The following is a description of a gene set: Comprehensive identification of all functional elements encoded in the human genome is a fundamental need in biomedical research. Here, we present a comparative analysis of the human, mouse, rat and dog genomes to create a systematic catalogue of common regulatory motifs in promoters and 3' untranslated regions (3' UTRs). The promoter analysis yields 174 candidate motifs, including most previously known transcription-factor binding sites and 105 new motifs. The 3'-UTR analysis yields 106 motifs likely to be involved in post-transcriptional regulation. Nearly one-half are associated with microRNAs (miRNAs), leading to the discovery of many new miRNA genes and their likely target genes. Our results suggest that previous estimates of the number of human miRNA genes were low, and that miRNAs regulate at least 20% of human genes. The overall results provide a systematic view of gene regulation in the human, which will be refined as additional mammalian genomes become available. Genes having at least one occurrence of the highly conserved motif M26 TTAYRTAA in the regions spanning 4 kb centered on their transcription starting sites. This matches the NFIL3 transcription factor binding site V$E4BP4_01 (v7.4 TRANSFAC). from publication Xie X, Lu J, Kulbokas EJ, Golub TR, Mootha V, Lindblad-Toh K, Lander ES, Kellis M (PMID 15735639) species: Homo sapiens Human Gene Set: TTAYRTAA_E4BP4_01, and this is the list of marker genes: NEGR1, PELI2, BSN, NPTX2, ZBTB7A, SLC24A2, SPRED1, AK3, SMAP2, ETV5, ETV4, FBXW7, SECISBP2L, NEUROD6, NMT1, MID1IP1, MED12L, FKRP, WDR47, CREB5, WDR81, LARP7, SYT14, SUMO1, ERGIC1, IL34, PRDM8, STK35, ARG2, H1-5, C1QTNF7, ELOVL6, CYLD, KCNIP4, MSRB3, CDK8, CALM1, YTHDF3, RGS6, FST, ARRDC3, FAIM2, NFIL3, GPM6A, RSKR, ANKRD40, CTDSP2 (CTD small phosphatase 2), PGK1, RBFOX2, LONRF3, UNC5C, HS6ST2, CREBRF, LHX6, DAGLA, INPP4A, PCSK2, BCL11A, PPFIA1, WEE1, NPTX1, CADM1, NRSN1, RASL10B, MIOX, ENAM, GNPNAT1, HERPUD1, DPM1, NDST3, TFEB, ALDH1A1, CFAP161, SIAE, NAPEPLD (NCBI Gene Id 222236), RGL1, ZDHHC14, PTHLH, FAM76A, ID4, MAP2K3, TSC22D1, AP1S2 (NCBI Gene Id 8905), MOCS3, USP2, EIF2A, RNF145, ASIC2, PALS2, AHNAK, SIDT1, FRY, C1orf122, RCC2, SLC22A8, ING1, ABHD8, UBR5, ELAVL4, SPA17, LMO4, IRAK1, PALS1, NAA60, EYA1, SERPINE2, HOXA4, DGKI, CRIM1, POGZ, ATXN1, ENSG00000291228, TREX1, UBE2H, ALDH3A1, PRRG3, IMPDH1, FGF14, LAMP5, OSBPL6, TFDP2, SH2B3, FUT9, ZNF638, ZFYVE9, CLVS1, LINC00472, FBXO3, ARNT, TNFSF13, CYCS, TBX6, ZBTB9, MACO1, AMY2A (amylase alpha 2A), TOB1, HIVEP3, DMD, AKTIP, CEP95, EPHX4, WNK2, G6PC1, ALB, SPRY4, CLCN1 (NCBI Gene Id 1180), MKNK2, H3-3A, DDX5, CRTAC1, ZNF572 (zinc finger protein 572), NECTIN1, EPB41, SERP1 (stress associated endoplasmic reticulum protein 1), WNT8B, OTP, JMJD1C, PURA, CNTF, LARGE1, LRRTM3, KLF9, ADNP, YWHAG, STK31, ANO1, PRKAG1, EPN2, IL1RAPL1, ZHX2, IGSF9B (NCBI Gene Id 651495), HECTD2, GRHL1 (NCBI Gene Id 29841), IRF2BP1, CAPS, MYLK, GABRR2, MCTP1, SH3GL2, MIR22HG, NTN5, TRIM8, NMT2, PDP1, RAB3C, CIART, TMEM126B, TMCC1, LGSN, TFAP2B, CHIC2, NIPBL, KCNJ1, ADRB2, ZDHHC5, MAP2K6, ZBTB14, MCTP2, PRNP, MPP2, KIAA1549L, GPBP1, JPH3, SPATA2, CLSTN1, NR1D1, NREP, PER2, CD40LG, EP300, BCL6, TSPAN7, CDKL1, SAMTOR, TMEM185A, OAZ3, SYT6, NYX, TSC22D3, DNAJA2, MECP2, IP6K2, RHOBTB2, SULF1, RAP2B, A1CF, ATP2A3, ASIC5 (NCBI Gene Id 51802), PRKG1, SLC35C2, SEC14L3, KCNJ13, ENPEP, RABL6, DENND4A, PRKAA2, ERF, COL15A1, MBNL2, PIK3R3, ARHGAP44, TAGLN3, HAND1, ANGPTL7, PPARG, STARD13, ARID1B, PIP4K2B, ASF1A, KMT2E, CX3CL1, UTRN, CSNK1E, DCAKD, PRICKLE1, IKZF2, LINC00671, LGALSL, DPYSL2, TNS2, SKIDA1, PREX2, HRH3, FNBP1, NOS1, GABARAPL2, IL6ST, YRDC (yrdC N6-threonylcarbamoyltransferase domain containing)